The following is a description of a gene set: part of: Cellular responses to stress studied in species Homo sapiens In response to exposure to elevated temperature and certain other proteotoxic stimuli (e.g., hypoxia, free radicals) cells activate a number of cytoprotective mechanisms known collectively as "heat shock response". Major aspects of the heat shock response (HSR) are evolutionarily conserved events that allow cells to recover from protein damage induced by stress (Liu XD et al. 1997; Voellmy R & Boellmann F 2007; Shamovsky I & Nudler E 2008; Anckar J & Sistonen L 2011). The main hallmark of HSR is the dramatic alteration of the gene expression pattern. A diverse group of protein genes is induced by the exposure to temperatures 3-5 degrees higher than physiological. Functionally, most of these genes are molecular chaperones that ensure proper protein folding and quality control to maintain cell proteostasis.<p>At the same time, heat shock-induced phosphorylation of translation initiation factor eIF2alpha leads to the shutdown of the nascent polypeptide synthesis reducing the burden on the chaperone system that has to deal with the increased amount of misfolded and thermally denatured proteins (Duncan RF & Hershey JWB 1989; Sarkar A et al. 2002; Spriggs KA et al. 2010).<p>The induction of HS gene expression primarily occurs at the level of transcription and is mediated by heat shock transcription factor HSF1(Sarge KD et al. 1993; Baler R et al. 1993). Human cells express five members of HSF protein family: HSF1, HSF2, HSF4, HSFX and HSFY. HSF1 is the master regulator of the heat inducible gene expression (Zuo J et al. 1995; Akerfelt M et al. 2010). HSF2 is activated in response to certain developmental stimuli in addition to being co-activated with HSF1 to provide promoter-specific fine-tuning of the HS response by forming heterotrimers with HSF1 (Ostling P et al. 2007; Sandqvist A et al. 2009). HSF4 lacks the transcription activation domain and acts as a repressor of certain genes during HS (Nakai A et al. 1997; Tanabe M et al. 1999; Kim SA et al. 2012). Two additional family members HSFX and HSFY, which are located on the X and Y chromosomes respectively, remain to be characterized (Bhowmick BK et al. 2006; Shinka T et al. 2004; Kichine E et al. 2012).<p>Under normal conditions HSF1 is present in both cytoplasm and nucleus in the form of an inactive monomer. The monomeric state of HSF1 is maintained by an intricate network of protein-protein interactions that include the association with HSP90 multichaperone complex, HSP70/HSP40 chaperone machinery, as well as intramolecular interaction of two conserved hydrophobic repeat regions. Monomeric HSF1 is constitutively phosphorylated on Ser303 and Ser 307 by (Zou J et al. 1998; Knauf U et al. 1996; Kline MP & Moromoto RI 1997; Guettouche T et al. 2005). This phosphorylation plays an essential role in ensuring cytoplasmic localization of at least a subpopulation of HSF1 molecules under normal conditions (Wang X et al. 2004).<p>Exposure to heat and other proteotoxic stimuli results in the release of HSF1 from the inhibitory complex with chaperones and its subsequent trimerization, which is promoted by its interaction with translation elongation factor eEF1A1 (Baler R et al. 1993; Shamovsky I et al. 2006; Herbomel G et al 2013). The trimerization is believed to involve intermolecular interaction between hydrophobic repeats 1-3 leading to the formation of a triple coil structure. Additional stabilization of the HSF1 trimer is provided by the formation of intermolecular S-S bonds between Cys residues in the DNA binding domain (Lu M et al.2008). Trimeric HSF1 is predominantly localized in the nucleus where it binds the specific sequence in the promoter of hsp genes (Sarge KD et al. 1993; Wang Y and Morgan WD 1994). The binding sequence for HSF1 (HSE, heat shock element) contains series of inverted repeats nGAAn in head-to-tail orientation, with at least three elements being required for the high affinity binding. Binding of the HSF1 trimer to the promoter is not sufficient to induce transcription of the gene (Cotto J et al. 1996). In order to do so, HSF1 needs to undergo inducible phosphorylation on specific Ser residues such as Ser230, Ser326. This phosphorylated form of HSF1 trimer is capable of increasing the promoter initiation rate. HSF1 bound to DNA promotes recruiting components of the transcription mediator complex and relieving promoter-proximal pause of RNA polymerase II through its interaction with TFIIH transcription factor (Yuan CX & Gurley WB 2000).<p>HSF1 activation is regulated in a precise and tight manner at multiple levels (Zuo J et al. 1995; Cotto J et al. 1996). This allows fast and robust activation of HS response to minimize proteotoxic effects of the stress. The exact set of HSF1 inducible genes is probably cell type specific. Moreover, cells in different pathophysiological states will display different but overlapping profile of HS inducible genes. Reactome Pathway: Cellular response to heat stress, and this is the list of marker genes: HSPA8, SEH1L, HSPA2, HSPA13, HSPA4, NUP133, NUP58, CAMK2D, GML, HSBP2, HSPA6, HSP90AB1, HSPH1, EP300, HSPA7, HSPA12A, HSF1, RANBP2, HSP90AA1, MAPK1, HSPA1L, RAE1, NUP43, NUP42, NUP37, NUP155, HSPA12B, MLST8, NUP98, BAG1, RPTOR, RPS19BP1, COL4A6 (NCBI Gene Id 1288), POM121, AAAS, SERPINH1, HIKESHI, DNAJC7, NUP160, RPA1, EEF1A1, BAG2, ST13, HSPB1, NUP62, HSPA9, FKBP4, POM121C, DNAJC2, NUP210, NUP188, UBB, NUP93, CREBBP, NDC1, CAMK2B, NUP214, CRYAB, NUP107, SEC13, AKT1S1, NUP88, MTOR, ATR, DEDD2, HSPB2, CAMK2G, ATM (ATM serine/threonine kinase), MAPK3, TPR, CAMK2A, RLN1, PTGES3, HSPA1B, HSBP1, HSPA14, TNFRSF21, YWHAE, NUP50, RPA3, NUP153, HSPA5, RPA2, HSPA1A, BAG5, MRPL18, MAPKAPK2, NUP85, DNAJB1, BAG3, HDAC6, BAG4, CCAR2, NUP35, HSPB8, CRYBA4, VCP, NUP205, GSK3B, NUP54, SIRT1, DNAJB6, HSPA4L